Given this list of marker genes MLF2 (myeloid leukemia factor 2), PPARG, ORMDL3, MOCS2, PLA2G15, GPRC5B, ABHD1, SORT1, H2BC4, PXMP4, TMEM33, KLF15, SCARB2, FABP4, KSR1, ABHD15, MKNK2, CD302, HIBADH, LTBP3, PRNP, SLC25A46, PEX5, CERK, REEP5, PNPLA2, SLC66A3, SCD, LIN52, COQ8A (coenzyme Q8A), FADS2, AOX1, ATOSA, DRAM2, PLEKHF2, ATP5MC3, QDPR (quinoid dihydropteridine reductase), IFNGR1, PCCA, IDH1, EEIG1, AFTPH, LPL, ATP1B3, KLHL25, PC, SELENOP, PANK3, LRRC8D, GCSH, NMT1, TTYH2, IMMT, ZNF219, FDX1, BCAR3, PPM1B, PIM3, BAZ2A, GHITM, FAM13A, CPEB3, NDUFS6, MTUS1, NCBP1, HIBCH, DGAT1, CYRIB, SCAF1, LSM12, ADIPOR2, XRCC3, ACSL3, ACADM, FBXO8, STOM, DAB2IP, ACAA2, CHPT1, PCYOX1, GUCD1, KAT2B, PUS10, EIF4G3, TANK, HADH, GINM1, YPEL5, NATD1, ALDH6A1, PEX3, CHP1, HSDL2, BFAR, NFE2L1, PFKL, ATN1, TMCC3, PAM16, MTCH2, CS, CSAD, ETFB, SLC1A5 (solute carrier family 1 member 5), CHCHD3, PLOD1, KMT5A, PFKFB1, APMAP, CERS4, ALAD, G3BP2, NABP1, LIPE, ESRRA, SELENOI, AGPAT2, TOB2, ATG101, CYTH1, SFXN1 (sideroflexin 1), BCL2L13, PLAAT3, NR1D1, ACOX1, TXLNG, EVI5L, ADIPOQ, ERP29, LONP2 (NCBI Gene Id 83752), PLA2G6, MSMO1, MAPKBP1, PLCB1, PTGR2, MPC2, JAGN1, BCAT2, ABCC4, ADAMTS12, AP3S1, PARL, SLC48A1, EFR3A, RASA3, HSD17B12, ATP5PF, here is a description of the gene set: Genes with promoters bound by both PPARG and RXRA at 8 (but not 0) day time point of adipocyte differentiation of 3T3-L1 cells (preadipocyte) and that were newly modified by H4K20me1. studied in species Mus musculus from publication Wakabayashi K, Okamura M, Tsutsumi S, Nishikawa NS, Tanaka T, Sakakibara I, Kitakami J, Ihara S, Hashimoto Y, Hamakubo T, Kodama T, Aburatani H, Sakai J (PMID 19414603) Human Gene Set: WAKABAYASHI_ADIPOGENESIS_PPARG_RXRA_BOUND_WITH_H4K20ME1_MARK Control of cell differentiation occurs through transcriptional mechanisms and through epigenetic modification. Using a chromatin immunoprecipitation-on-chip approach, we performed a genome-wide search for target genes of peroxisome proliferator-activated receptor gamma (PPAR gamma) and its partner protein retinoid X receptor alpha during adipogenesis. We show that these two receptors target several genes that encode histone lysine methyltransferase SET domain proteins. The histone H4 Lys 20 (H4K20) monomethyltransferase PR-Set7/Setd8 gene is upregulated by PPAR gamma during adipogenesis, and the knockdown of PR-Set7/Setd8 suppressed adipogenesis. Intriguingly, monomethylated H4K20 (H4K20me1) levels are robustly increased toward the end of differentiation. PR-Set7/Setd8 positively regulates the expression of PPAR gamma and its targets through H4K20 monomethylation. Furthermore, the activation of PPAR gamma transcriptional activity leads to the induction of H4K20me1 modification of PPAR gamma and its targets and thereby promotes adipogenesis. We also show that PPAR gamma targets PPAR gamma2 and promotes its gene expression through H4K20 monomethylation. Our results connect transcriptional regulation and epigenetic chromatin modulation through H4K20 monomethylation during adipogenesis through a feedback loop.